Given this list of marker genes Cbr4, Kcne1, Aasdhppt, Smap1, Ep300, Pdzrn4, Zfp629, Fancf, Spcs2, Rab10, Glyctk, Pxdn, Exoc6b, Mnat1, Far1, Htr4, Kcnma1, Cyp2c50, Nxf3, Aldh2, Aspm (abnormal spindle microtubule assembly), Cyp2j11 (cytochrome P450, family 2, subfamily j, polypeptide 11), Ccnc, Tmem30b, Nploc4, Cacul1, Grip1, Nlrp6, Fgf15, Gata3, Gstm2, Trim16, Dcbld2, Sall2, Zmynd19, here is a description of the gene set: Mouse Gene Set: MIR_135A_1_3P from publication Chen Y, Wang X (PMID 31504780) Genes predicted to be targets of miRBase v22 microRNA mmu_miR_135a_1_3p in miRDB v6.0 with MirTarget v4 prediction scores > 80 (high confidence targets). studied in species Mus musculus